The following is a description of a gene set: studied in species Homo sapiens Human Gene Set: GOMF_HSP90_PROTEIN_BINDING Binding to Hsp90 proteins, any of a group of heat shock proteins around 90kDa in size., and this is the list of marker genes: GBP1, PTGES3L, NR3C1, GUCY1B1, CYP2E1, PPEF2, KPNB1, STUB1, EIF2AK3, CDK5, UNC45A, AHR, PPID, RPS3, TSC1, CSNK2A1, PACRG, CYP1A1, USP19, TELO2, NOD2, CDC37, PTGES3, FKBP6, HSF1, BMAL1, TSC2, AHSA1, NUP62, ERN1, NPAS2, STIP1, PPP5C (protein phosphatase 5 catalytic subunit), SLC12A2 (NCBI Gene Id 6558), HDAC6 (NCBI Gene Id 100820762), HDAC8, CHORDC1, KDR, MAPT, TTC4, UNC45B, HIF1A